The following is a description of a gene set: The multiplication or reproduction of osteoclasts, resulting in the expansion of an osteoclast cell population. An osteoclast is a specialized phagocytic cell associated with the absorption and removal of the mineralized matrix of bone tissue, which typically differentiates from monocytes. species: Homo sapiens Human Gene Set: GOBP_OSTEOCLAST_PROLIFERATION, and this is the list of marker genes: TCIRG1, GREM1, TNFAIP3, JUNB, NMB, TNFSF11, PHF7, NPR3, NMBR, PTH, CSF1, OCSTAMP